The following is a description of a gene set: Mouse Gene Set: GOBP_POSITIVE_REGULATION_OF_SYSTEMIC_ARTERIAL_BLOOD_PRESSURE studied in species Mus musculus The process that increases the force with which blood travels through the systemic arterial circulatory system., and this is the list of marker genes: Cyp2j5, Manf, Rhoa, Hsd11b2, Adora1, Nmu (NCBI Gene Id 56183), Avpr2 (NCBI Gene Id 12000), G6pdx, Ace, Avp, Adra1b, Rarres2, Adrb1, Spx (NCBI Gene Id 319552), Adra1a (NCBI Gene Id 11549), Cyp11b2, Avpr1a, Wnk1, Nr3c2, Ptpn1, Camk2n1, Agt, Eng, Nr2f2, Ace3, Cyba, Chrna7